Given this list of marker genes Itih2, Gm13293, 4930505K14Rik, Glis3, Pga5, Lims1, Bcas3os2 (BCAS3 microtubule associated cell migration factor, opposite strand 2), Cir1, here is a description of the gene set: species: Mus musculus Mouse Gene Set: NFIC_TARGET_GENES from publication Yevshin I, Sharipov R, Kolmykov S, Kondrakhin Y, Kolpakov F (PMID 30445619) Genes containing one or more binding sites for (Nfic) in their promoter regions (TSS -1000,+100 bp) as identified by GTRD version 20.06 ChIP-seq harmonization.